Given this list of marker genes Cecr2, Dpf3, Bicra, Bicral, Smarcc2, Actr6, Atp6ap2, Dpf2, Atp6v0d2, Smarcd2, Atp6v0b, Smarca4, Smarcc1, Cdk2ap1, Dpf1, Pole3, Chd5, Actl6b (actin-like 6B), Srcap, Bcl7b, Ino80e, Luzp1, Tfpt, Bcl11b, Atp6v1g1, Smarca1, Atp6v1f, Pbrm1, Ss18l1, Arid2, Cfdp1, Atp6v0d1, Smarcd3, Ing3, Atp6v0a2 (NCBI Gene Id 97206), Chrac1, Baz2a, Mbd2, Atp6v0e, Smarca5, Vcp, Atp6v1e1, Phf10, Chd4, 0610010K14Rik, Ercc6, Rbbp7, Vps4b (NCBI Gene Id 319619), Hdac1, Atp6ap1l, Arid1a (NCBI Gene Id 93760), Atp6v1a, Smarcb1, Bcl7a, Hdac2, Atp6v1b1, Nfrkb, Brd8, Brd7, Tcirg1, Ddx21, Mta1, Ino80c, Atp6v0a1, Atp6v1h, Myo1c, Anp32e, Atp6v1g3, Atp6v1c1, Ptpa, Bcl11a, Brd9, Atp6v1g2, Kat5, Chd3, Sall1, Ruvbl2 (NCBI Gene Id 20174), Ino80, Uchl5, Arid1b, Smarca2 (NCBI Gene Id 67155), Atp6v0a4, Cdk2ap1rt, Atp6v1b2, Ss18, Ruvbl1, Atp6v0c, Atp6ap1, Atp6v0e2, Smarce1, Mta2, Spaar, Actr8, Smarcd1, Gatad2a, Mta3, Sf3b1, Mcrs1, Actb, Cdk2ap2, Rsf1, Mybbp1a, Mbd3, Ep400, Bcl7c, Atp6v1d, Actr5, Baz1a, Actl6a, Gon4l, Bptf, Rnasek, Trrap, Tmem199, Atp6v1c2 (NCBI Gene Id 68775), Znhit1, Yy1, Dmap1, Baz1b, Ino80b, Dek, Hmgxb4, Ino80d, Gatad2b (NCBI Gene Id 404569), Rbbp4, Vps4a, Suz12, Ccdc115, here is a description of the gene set: Mouse Gene Set: GOCC_ATPASE_COMPLEX A protein complex which is capable of ATPase activity. studied in species Mus musculus